Given this list of marker genes MMP2, ADRA2B, MIR21, H3-3A, MIR16-1, MMP9, SMAD2, KLF1, SPP1, TIMP1, CALR, PLA2G4C, ABCB1, CORIN, H3-3B, SEMG1, GARIN3, UCN, HMX3, RPL29, TEKT3, CAD, PSG11, PLA2G4B, TRO, CLIC5, HSD11B2, RARA, STAT5B, PPARD, CYP27B1, CRH, HYAL3, CBS, THBD, KLK14, LIF, SPHK2, CITED2, RECK, ACVR2B, ITGB3, FOSB, CALCA, FKBP4, VDR, MED1, PGR, STOX2, RLN1, PTN, LGALS9, RXFP1, PSG3, LEP, IL11RA, CAPN2, TRIM28, IL1B, C1QBP, EMP2, ACOD1, GNRH1, ERRFI1, SMURF2, GJA1, PNOC, SLC38A2, BMPR2, ADRA2A, HEXB (NCBI Gene Id 3074), PTHLH, DSG1, MAGED2, UBE2Q1, PCSK5, WNT4, INTS1, HPGD, TACR1, RLN2, SLC38A3, PRLHR, UBTFL1, FSHB, PZP, SERPINE2, MSTN, PSG4, STC1, IGFBP2, IGFBP5, OVGP1, YTHDF3, GHRL, COL16A1, TNP2, NDP, LDOC1, GNAS, HSF1, OXT, FBLN1, ACE2, DSG2, MIR15B, PSG1, POLR1B, SCGB1A1, CTSB, RGS2, ANGPT2, FOS, PRL, PPP3R2, PSG2, CRHR1, EDN1, STC2, SLC19A1, ITGA2, VEGFA, AR, AMBP, ITGA3, IHH, NODAL, TEAD3, TCF23, STS, TEAD4, PSG9, ACVR1B, SYDE1, APELA, PRDM14, ITGB4, GHSR, TPPP3, PITHD1, B4GALT1, PTGIS, APOL2, GARIN4, AGO2 (argonaute RISC catalytic component 2), PARP2, PTGS2, ITGA5, PSG6, EPN1, ADCY7 (adenylate cyclase 7), PSG5, SOD1, APLF, TGFB1, ENSG00000274276, KPNA6, DDO, ACVR2A, HSPG2, DAZAP1, PRDM1, NPFF, SMCP, PRDX3, PARP1, NR2F2, LNPEP, RXRB, PTGFR, UPRT, FBN2, ESR1, JUNB, GRN, TGFBR1, P2RX1, TLE6, FUT7, EPYC, ACR, AGRP, ARHGDIB, LAMB1, EDDM3A, DEDD, A1CF, IGFBP7, TAC3, OXTR, AVPR1A, IDO1, TAC1, STAT5A, EPO, NPPA, PSG7, CLDN4 (NCBI Gene Id 1364), TMED2, HAVCR2 (hepatitis A virus cellular receptor 2), DDR1, ACVR1C, ADCYAP1, CSMD1, BSG, CD38, SLC2A1 (solute carrier family 2 member 1), BCL2, CRHBP, MAFF, AKT1, ASH1L, SP3, VMP1, SMAD3, DCAF13, PAPPA (pappalysin 1), ABCC8, SLC38A1, EPOR, PRLR (NCBI Gene Id 5618), DKKL1, KRAS, ACSL4, ENDOU, CYP1A1, here is a description of the gene set: Human Gene Set: GOBP_MULTI_MULTICELLULAR_ORGANISM_PROCESS studied in species Homo sapiens A multicellular organism process which involves another multicellular organism of the same or different species.